Given this list of marker genes Calb1 (NCBI Gene Id 12307), Pax8, Umod, Pax2, Pou3f3, here is a description of the gene set: The process whose specific outcome is the progression of the distal convoluted tubule over time, from its formation to the mature structure. The distal convoluted tubule is the first segment of the nephron lying just downstream from the loop of Henle, immediately after the macula densa. Among other functions, in humans it is responsible for the reabsorption of about 5% of filtered sodium via the thiazide-sensitive Na-Cl symporter. Mouse Gene Set: GOBP_DISTAL_CONVOLUTED_TUBULE_DEVELOPMENT studied in species Mus musculus